The following is a description of a gene set: A better molecular characterization of breast cell lines (BCL) may help discover new markers to apply to tumour samples. We performed gene and protein expression profiling of 31 BCL using whole-genome DNA microarrays and immunohistochemistry (IHC) on 'cell microarrays' (CMA), respectively. Global hierarchical clustering discriminated two groups of BCL: group I corresponded to luminal cell lines, group II to basal and mesenchymal cell lines. Correlations with centroids calculated from a published 'intrinsic 500-gene set' assigned 15 cell lines as luminal, eight as basal and four as mesenchymal. A set of genes was differentially expressed between basal and luminal samples. Mesenchymal and basal subtypes were rather similar and discriminated by only genes. The expression of 10 proteins (CAV1, CD44, EGFR, MET, ETS1, GATA3, luminal cytokeratin CK19, basal cytokeratin CK5/6, CD10, and ERM protein moesin) encoded by luminal vs basal discriminator genes confirmed the subtype classification and the validity of the identified markers. Our BCL basal/luminal signature correctly re-classified the published series of tumour samples that originally served to identify the molecular subtypes, suggesting that the identified markers should be useful for tumour classification and might represent promising targets for disease management. Genes up-regulated in luminal-like breast cancer cell lines compared to the basal-like ones. from publication Charafe-Jauffret E, Ginestier C, Monville F, Finetti P, Adélaïde J, Cervera N, Fekairi S, Xerri L, Jacquemier J, Birnbaum D, Bertucci F (PMID 16288205) studied in species Homo sapiens Human Gene Set: CHARAFE_BREAST_CANCER_LUMINAL_VS_BASAL_UP, and this is the list of marker genes: NACA, RSPH1 (radial spoke head component 1), KATNIP, SLC25A44, SNX27, RSAD1, MYEF2, MTCL2, PI4KA, MEGF9 (multiple EGF like domains 9), TRAPPC9, PRRC2C, ANXA9, PCK2, CTXN1, MXRA8, GPD1L, GSPT1, HID1, MYCN, RHBDF1, AFF3, PCBP2, SLC38A1, GALNT6, SLC25A29, EIF3B (eukaryotic translation initiation factor 3 subunit B), CRACD, THUMPD1, TBC1D30, PRRT2, TAPT1, FGFR4, SEC16A, PLA2G12A (NCBI Gene Id 81579), TJP3, GGA3, ANKRD13D, ADGRB2, DENND1A, RAB11FIP3, POLE, MIF4GD, ZNF12, MGAT4A, GPRC5C, VPS72, ABCG1, PRLR, MB21D2, KLHDC9, TOMM70, TOB1, IRGQ, TMEM80, GOLT1A, SYNGR2, ABCA3 (NCBI Gene Id 21), TLE3, ZFYVE16, ASTN2, CYB561, KAT6B, CIRBP, SMARCC2, PLXNA3, PLEKHH1, SHTN1, TTC3, ANKRD30A, FKBP4, MLPH, KDELR2, NDUFS8, SMIM14, ADCY6, ATP6AP1, SECISBP2, DHRS13, ATP8B1 (NCBI Gene Id 5205), P4HTM, LARGE1, REEP5, ARHGEF26, DIP2C, LZTR1, IQSEC1, LUC7L3, SFMBT2, PKP4, CRNKL1, SOX12, C14orf132, PRKAG1, TBX3, RUSC1, HEXD, CISH, STRADA, DLG3, TRIL, CXXC5, MAGED2, SBK1, ELAPOR1, BPTF, CCDC117, TGIF2, ETNK2, TTC9, DEGS2, ARRB1, DSCAM-AS1, SIDT1, TFF1, MYO6, GATA3, ARFIP2 (NCBI Gene Id 23647), CERS6, PBX1, LIN7A, NME3, CREB3L1, SLC16A6, TESK1, ONECUT2 (one cut homeobox 2), LONRF2, CSNK1D, ELOVL2, FTX, ELL3, GARS1, SPDEF, GAMT, IVD, KMT2D, DEPTOR, SCUBE2 (NCBI Gene Id 57758), PRRT3, PCP4, DNAJA4, TTC39A, ERBB3, TBC1D16, FAM234B, CCT6P3, USP7, IQCE, TESMIN, STRBP, SLC7A8, RALGPS1, CHTOP, GTF3C1, PREX1, TC2N, KRT19, ISG20, CADM1, RUBCN, BCAS1, TMEM268, EPS8L1, SPTLC2, CACNG4, POGZ, CACNB3, HMG20B, PLCXD1, DDAH2, ERGIC1, VPS37C, CACNA2D2, SLC37A1, ARFGEF3, ZMIZ1, PGR, CCND1, FUS (NCBI Gene Id 406232), ANXA6, POMT1, CACNA1D, RIPOR3, INPP5J, ARID3A, FAM110B, CYBC1, SLC2A10, SCYL3, GSE1, DAAM1, KCTD15, ABHD11, MACO1 (macoilin 1), FRMD4A, RND1, ULK1, TENT5C, DNALI1, CHDH, TMEM229B, KIF12, TADA2B, ZNF74, F7, SLC27A3, PATZ1, RALGAPA1, ASH1L, ATP2C2, TFF3, ZNF398, SLC4A8, NLK, KDM4B, SRRM2, C17orf58 (chromosome 17 open reading frame 58), SOX13, GARNL3, ATP6V0E2, C9orf152, CREB3L4, RHPN1, KDM7A, MYB, FBRSL1, ZNF24, LMCD1, HK2, HMGCS2, EFR3B, DDX42, FZD4, ICA1, ARID2, TRPS1, ACVR1B, CAPN9, ZBTB42, EPN3, MCCC2, UAP1L1, MAPK9, USP42, NHERF1, KLF2, SLC38A10, ENPP1, C4orf19, PPP2R2C, CAMSAP3, NUDT4, TNIP1, CA12, SFI1, ZNF444, SLC44A4 (NCBI Gene Id 87892), INTS15, VIPR1, NECTIN2, AMZ1, PPP1R16A, SLC26A11, KIAA0232, HPX, FRS2, TSPAN15 (tetraspanin 15), ABHD12, SERF2, RABEP2, RNU6-1016P, DENND4B, DUSP8 (dual specificity phosphatase 8), USP3, SYCP2, ZNF703, NEK5, LINC01128, DNAJC1, SPMIP5, GATA3-AS1, ZNF84, PGGT1B, WFS1, DACH1, AGR2, MGRN1, CACYBP, SHANK2, RHOB, CERS2, CSRNP2, RGL2, SH3GLB2, INHBB, ZSWIM8, TMEM150C, MAPT, SIDT2, ENTR1, NKAIN1, RAB40C, CHN2, RBAK, FOXA1, LRRN1, CACFD1, CDYL2, TCAF1, AR, CDC42SE1, HECTD4, AVL9, GPR160, PRR36, ARF3, CFD, LCOR, LNX1, CTNND2, ATXN7L3B, SLC24A3, STARD10, SNED1, KIAA0040, EMP2, ASB8, CEP350, PYCR1, TMEM184A, PPFIA1, TGFB3, ZNF467, KIFC2, LLGL2, RIIAD1, NUCB2, TRIM3, RNF103, GGA1, PDCL3, TMBIM6, SLC1A4, GRAMD4, TNRC18, ZNF296, BCOR, ZNF704, GP1BB (glycoprotein Ib platelet subunit beta), BLNK, DOP1B, SLC35A1, PRR14, MTERF2, TMEM276, CLSTN2, BAZ2A, RAB3D, MDM4, RAB17, GART, TBL1X, TSPAN13, EVL, SYNE4, UBN1, ESR1, LMNTD2-AS1, MYO5B, KLHL22, HPN, TTC6, HIP1R, CANT1, LFNG (NCBI Gene Id 3955), MARS1, SPATA2L, RDH13, ENSG00000280119, LARP4B, HNRNPA2B1, NPDC1, LRP3, THSD4